The following is a description of a gene set: studied in species Homo sapiens Renal agenesis Human Gene Set: HP_RENAL_AGENESIS Agenesis, that is, failure of the kidney to develop during embryogenesis and development., and this is the list of marker genes: PPP2R1A, ADGRG2, ERCC8, WDR62, SON, MCM7, IL17RD, FAM149B1, ERCC6, RTTN, DUSP6, RPL5, GFRA1, SARS1, WNT4, FLRT3, TBC1D24, SOX10, TSR2, PROK2, ATRX, FGFR2, GNB2, CTU2, RPS19, KMT2D, PIEZO2 (NCBI Gene Id 63896), RPL35, SALL4, KNL1, TFAP2A (transcription factor AP-2 alpha), SRCAP, RAP1B, WARS1, CDON, FEZF1, CFTR, ITGA8, RPS20, ZMYM2, TBX1, DLL1, DCC, TBXT, TP63, GRIP1, TMEM67, KCTD1, KYNU, ROBO1, GDF6, GLI3, RPS10, RPS15A, RPL8, STS, ZIC2, FGF20, RPL18, METTL5, TOPORS, FANCE, TRAPPC10, NCAPD3, FANCB, LRP4, MAX, RPS7, NSD1, SH2B1, RPS26, PPP2R3C, RPL15, PTCH1 (patched 1), RPL31, FANCL, MKS1, NUP37, PTPN11, FGF8, GAS1, ASXL2, APC2, RPS28, POR (cytochrome p450 oxidoreductase), GREB1L, STX5, TACR3, FGF17, NADSYN1, FOXH1, SPRY4, THOC6, WBP11, RPL11, DHCR24, ANKRD17, FANCD2, TXNL4A, RPL35A, GATA3 (GATA binding protein 3), TRPV6, RET, DISP1, FANCC, TNXB, TGIF1 (NCBI Gene Id 91941), WNT3, PALB2, RPS27, XRCC4 (X-ray repair cross complementing 4), HEATR3, PDE6D, SIX1, TCTN3, NODAL, TMEM216, SEMA3A, SHH, HOXD13, WNT9B, RPL27 (NCBI Gene Id 6155), DHCR7, HNF1B, COPB2, FANCA, PPFIBP1, PIK3CD, KDM6A, WLS, LMBRD1, ZIC3, FBLN5, CRELD1, CDK5RAP2, KIF7, FREM2, PBX1, ELN, SASS6, DSTYK, FREM1, KIF14, GATA1, KIAA0753, H4C9, WDR11, CDK6, FGFR1, KNSTRN, CEP152, TMEM231, CCDC141, TRAPPC14, TAF13, ALDH18A1, CRIPTO, SIX3, SCAF4, VANGL1, EYA1, PROKR2, PRKAR1A, CEP135, CIT, SDCCAG8, CCNQ, RPS29, PIK3C2A, HESX1, SF3B2, PHC1, ADA2, NDNF, CHD7, CEP63, IDH1, ATN1, MBTPS2, DYRK1A, RPL9, ANOS1, ANKLE2, SF3B4 (NCBI Gene Id 171), RPS24, RPL26, PHGDH, ALKBH8, CDC42, FUZ, PUF60, STIL, NSDHL, GLI2, MFSD2A, SUFU, COG6, CPLANE1, HS2ST1, OFD1, ASPM, INSL3, PYCR2, CENPE, HS6ST1, MCPH1, RPS17, TMCO1